The following is a description of a gene set: from publication Chen Y, Wang X (PMID 31504780) species: Homo sapiens Genes predicted to be targets of miRBase v22 microRNA hsa-miR-9-5p in miRDB v6.0 with MirTarget v4 prediction scores > 80 (high confidence targets). Human Gene Set: MIR9_5P, and this is the list of marker genes: SLC50A1, SPTLC2, AATK, HIPK1, SMARCD2, CNOT7, ZC3H10, AP1S2, CREBRF, GIT2, DNAJC14, EFNA1, MAP7, TGFBI, DYNC1I2 (dynein cytoplasmic 1 intermediate chain 2), TYW3, ZBTB20, KCNK4 (NCBI Gene Id 50801), ADAMTS6, PYGO2 (NCBI Gene Id 90780), MYH9, FBN2, KCNMB2, EGLN3, KCNJ14, IPO11, RALGDS, BBX, ADAMTS3, SLC19A2, ELAVL1, FNDC3B, UNC80, HLCS, SIX4, MARCHF6 (NCBI Gene Id 10299), NUTF2, TRPM7, EMB, MTMR2, SNX25, ENSG00000275993, MEF2C (NCBI Gene Id 4208), UBE3C, PDK4, RAB40B, SORT1, ANKRD29, PRTG, ZBTB41, ITM2C, SPATA16, ZNF395, MTHFD2, CLCA2, ATP8B2, PWWP3B, ESYT1, SPART, KLHL18, MAB21L3 (NCBI Gene Id 126868), MTHFD1L, ZDHHC21, PLBD2, SHROOM3, DLX3, SIX5, CNTN3, PPARA (NCBI Gene Id 84730), CCSER2, STK38L, ICMT, GRSF1, ARID1B, VANGL1, MICAL2, SYT4, ZBTB39, SLC31A2, ZNF354A, UBFD1, KIF13B, KIAA2013, NTNG1, IGF2BP2, MAP3K3, DNAJC3, GRIK3, TSC22D2, TRIM66, SLC9A1 (NCBI Gene Id 6548), TXNDC5, FRYL, ARMCX2, ZSWIM9, HMMR, ITGB4, GOLPH3, SETD9, GPBP1L1, NCOA7, FRMD6, TSPAN9, KIRREL1, ATOH8, MCMBP, TENM1, ONECUT2, PHLDB2, VAMP7, HLTF, ENPEP, ESYT3, SLC25A24 (solute carrier family 25 member 24), SERINC5, POU2F2, RHOQ, CPEB4, ADCY5, RXRA, FAM199X, RANBP17, DIPK2A, HCFC2, CCDC50, SMARCE1, NFATC3, FBRS, STK3, AP3B1, CHMP2B, CXCL11, FOXN2, BCAT2, ID4, SDC2, RAB34, GRWD1, PRPS2, FREM2, ATP11A, GABRB2, GLS, PIGM, SMAP2, SYAP1, EHD4, ULK2, MTR, PCSK2, TMEM87B, MAGT1, ANO1, OGDHL, TES (NCBI Gene Id 26136), TMEM260 (NCBI Gene Id 54916), LAMP1, NXPE3, MYPN, SLC7A8, MIER3, TENT5C, REEP3, NR5A2, ITPKC, ANKRD13A, ITIH6, SPON1, CCNE1 (NCBI Gene Id 898), CNMD, TMEM109, PARG, SMURF2, FNIP2, DOK6, CLOCK, FAM8A1, PPIP5K1, WASF2, OTUD3, MIS18A (MIS18 kinetochore protein A), MYO1C, TAFA4, CSNK1A1, POLR3G, HPS5, SHC1, PRDM1, PHF8 (NCBI Gene Id 57793), EIF4E3, PHIP, UBASH3B, PI4K2A, MMP16, MAEA, PMP22, SLC20A2, MRTFB, ERICH3, PLPP6, LYVE1, TMTC1, TMPRSS15, ADRA1A, FSTL1, TAF4B (TATA-box binding protein associated factor 4b), PGRMC2, ARK2N, DR1, SNX16, TNC, C16orf54, ITGA4, GOT1, FOXP4, LRRK2, CCNT2, UACA (NCBI Gene Id 55075), DDHD2, FYTTD1, SLC39A14, KCTD10, NEDD4, CCDC43, COG3, REST, SOCS5, CEP350, CDK8, TBC1D22A (TBC1 domain family member 22A), ATF1, ANK2, LMBRD2, DIO2, IFI44, FGF5, ATL2, POU2F1, PTAR1 (protein prenyltransferase alpha subunit repeat containing 1), NFIC (nuclear factor I C), PCGF6, PCGF5, FAM13C, MGA, CLDN14, PSD3, CSGALNACT1, COL15A1, AR, EOGT, NALF2, CRIM1, ESRRB, SACS, ASXL3, ADGRL1, C2orf15, RMND5A, MAPKAPK2, MDGA1, TESK2, MAP3K1, VAMP3, FURIN, STARD13, ARF6, UHMK1, EPHA7, SEPTIN10, ASXL1, ZKSCAN1, SGMS2, LMNA (NCBI Gene Id 7816, lamin A/C), NTAN1, IGF2BP3, PDE3B, MFSD14A (NCBI Gene Id 64645), P3H1, SLC44A5, VCL, VGLL4, INHBB, PNPT1, MEGF10 (multiple EGF like domains 10), STEAP3, MAP1A (microtubule associated protein 1A), TENM4, STAC, DSE, NHLH2, C11orf58, ONECUT1, FBXL2, CTNNA1, RTN4RL1, TENT5D, PTPRK, FOXP1, SYNJ1, CNOT6L, PRKG2, PAK3, COL27A1, LIN28B, PDGFRB, ITGBL1, SIK1, RPS6KA4, PCDH7, UBE2Z, PRDM6, CALB2, NRP1 (NCBI Gene Id 8829), THAP2, TBPL1, SGSM1, ARID1A, ST8SIA4, AUH, BTBD10, ASB7, UHRF1, ITM2B, JPT2, SLC6A2, AK4, PHF20L1, SCUBE2, CHMP1B, KIF13A (NCBI Gene Id 63971), BEND3, AP4E1, NEFH, SHROOM4, MRE11, SAMD8, TLK1, ZBED3, LRRTM4, SBNO1, PDE12, SYT1, ARHGDIA (NCBI Gene Id 396), DIXDC1, RBMS3, HUNK, LRRC39, PLPPR5, VDAC3, NID1, FBXL3, CMTM6, DCBLD2, SHTN1, TNS1 (NCBI Gene Id 7145), SLC10A3, ATF2, VAV3, IGFBP3, ATG14, FAM120A2P, MYOCD, TBC1D8, SIRT1, YBX3, DCUN1D4, PRRX1, HOXB13, SEC23IP, PTBP3, REEP4, BAG4, OTUD7B, CMTR2, SHROOM2, KITLG, DYRK1B, HYCC2, ASCL4, LZTS3 (NCBI Gene Id 9762), SLC6A6, SEC31A, ITGA6, THEMIS, TGFBR2, PLSCR3, IL33, AMMECR1, ARPC1A, ITPRIPL2, PCSK6, ARFGEF1, FLNB, RASSF3, C21orf91, CPEB3, BACE1, ABL2, ARHGEF2, OXSR1, TRERF1, CHST15, UTRN, TAFA5, SCYL3, RHOJ, KCNJ2, M6PR (mannose-6-phosphate receptor, cation dependent), RNF150, KLF5, C4orf46, FYCO1, ARHGEF17, BAHD1, CCNDBP1, CAPZA1, ZCWPW2, SLC8A1, DIAPH2, PRRT3, ALCAM, INSIG1, GDNF, DENND3, COL9A1, LDLRAP1, STT3B, TBC1D4, ADAMTS9, AMBRA1 (NCBI Gene Id 55626), RNF111, CCNG1, VCAN, FAM91A1, ZC3H12A, PIK3C2A, RALB, FBXW2, NCOA3, CDIN1, THRB, SLC5A3, HIPK3, PXDN, SFXN2, NID2 (NCBI Gene Id 95183), CC2D1B, GGPS1, GALNT1, LSM14A, IPO4, ARFGEF2, SNX7, B3GALNT2, MIGA2, CARD19, KCTD12, FBN1, CACNA1E, NOX4, FLRT3, MAP3K2, SLC39A9, PPM1F, GPR137C, FOXG1, RHOBTB1, TRAF3, MDGA2, CPEB2, TLNRD1, FKBP7, CREB5, NAF1, MYRFL, GALNT3, ACOT7, MAP1B (microtubule associated protein 1B), POU3F2, COLEC12, TRIM71, HIC2, PALMD